Given this list of marker genes PHLDA3, HIGD1A, LIMA1, WDR43, PCK2, SNAP25, ACTR1A, PDAP1, PRKAR2B, TRAK2, PCDH10, PCDHA13, FCHO2, GLT6D1, CFAP68 (NCBI Gene Id 737), ERMP1, PCDH11Y, PCDHA5, PSMD11, DYRK1A, ZC3H12C, REEP1, SNRPE, PCDHA1, SAXO1, FOXP2, RAB3B, FKBP5, PCDHA6, PPIA, EHF, COMMD6, RTL8C, ATXN1, RBPJ, XPO1, SSBP2, ANKRD12, SULF1, HSPB3, ARHGEF7, PAPOLB, THAP6, PKNOX1, CADM2, LSM14A, PTPRQ, USP10, CRKL, RBM27, AHDC1, PCDHAC1, EEIG2, HTR2C, CHD1, UBE3A, YPEL1, PCDHA12, PPM1D, PCDHA7, MTCL1, FIGNL2, RECK, RCOR3, GSPT1, MYLK, NAA16, TRIO, FN1, ARID4B, SCAMP1, SLC26A7, HLA-DPB1, PCDHA11, ZXDA, PCDH9, RSRP1, COL8A1, ZNG1E, ADCY2, SLC8A3, FAM3C, ZDHHC11, ASB7, ZEB1, PCDHA3, HMMR, NDUFB6, IGFBP1, MAP2, LIX1, YWHAZ, SPG11, QKI, DCAF10, RAB6C, RAB6A, ST8SIA3, TMEM255A, LIN7A, GJA1, CNOT7, PAM (peptidylglycine alpha-amidating monooxygenase), WDHD1, PCDHA2, TRIM33, KCNN3, PCDHA9, TCF12, XRCC5, STXBP5L, KLF5, CDYL2 (chromodomain Y like 2), PCDHA10, RHPN2, RAG1, ZMYND11, PCDHAC2, NCBP3 (NCBI Gene Id 55421), FAM53C, SGIP1, PCDHA4, RELCH, PIGH, NPTX1, UBE2B, OTUD4, here is a description of the gene set: species: Homo sapiens from publication Chen Y, Wang X (PMID 31504780) Genes predicted to be targets of miRBase v22 microRNA hsa-miR-892a in miRDB v6.0 with MirTarget v4 prediction scores > 80 (high confidence targets). Human Gene Set: MIR892A